The following is a description of a gene set: studied in species Homo sapiens Human Gene Set: GSE25087_FETAL_VS_ADULT_TREG_UP from publication Mold JE, Venkatasubrahmanyam S, Burt TD, Michaëlsson J, Rivera JM, Galkina SA, Weinberg K, Stoddart CA, McCune JM (PMID 21164017) We compared differences in fetal and adult T cells by performing whole genome profiling on sort-purified T cells (naïve CD4+ and Treg cells) from human fetal specimens (18-22 gestational weeks) and adult specimens (age 25-40 years old). Fetal and Adult Naïve CD4+ T cells phenotype: CD3+CD4+CD45RA+CCR7+CD27+, Fetal and Adult CD4+CD25+ Treg phenotype: CD3+CD4+CD25bright Genes up-regulated in comparison of fetal regulatory T cell (Treg) versus adult regulatory T cell (Treg)., and this is the list of marker genes: APOO, HSP90B1, VCP, KDM5B, MAN2A2, RAD21, SMCO4, LAMP3, NDUFB7, GRAMD1B, GSTP1, PIGY, BANF1, CSRNP1, HILPDA, YTHDF2, EVI5, SUCLA2, TNIP3, SLC25A43, TOX, CTPS1, KSR2, BTNL9, RAB43, TUBA1C, MAP3K20, CEP85, DHCR24, TRIO, DOLPP1, EPB41L2, AIF1, LRRC32 (leucine rich repeat containing 32), DNAH11, UBA2, PTGFRN, XPNPEP1, RRAS2, VDR, DACT1, NFKBIE (NFKB inhibitor epsilon), MREG, PLAG1, KHDRBS1, CASP3 (caspase 3), DYNC1I2 (dynein cytoplasmic 1 intermediate chain 2), RHOA, FAF2, STIP1, EVA1B, CXCL3 (C-X-C motif chemokine ligand 3), PTPRK, SLC18A2, DRAP1, CXCL1, NPM3, KIAA1586, NHS, GRK3, MACIR, CORO2B, VRK2, GTF2H5, CHCHD4 (coiled-coil-helix-coiled-coil-helix domain containing 4), PSME1, ACYP1, UTP14C, AGRN, EIF2S1, PRMT1, LINC00487, ZNF823, ADPRH, MCCC2, TMEM237, CDKN2B, GRHPR, HIC1, UBA5, GNB4, SLC25A20, ZNF404, FEN1, KLHL23, SCLT1, TRAF4, ZNF827, FURIN, RPA1, NDUFA9, CYP1A1, STAT1 (NCBI Gene Id 6772), ILDR2, ATF4, MRPL15, SIAH2, ACAA2, CMPK2, HNRNPK, LRRC59, RNGTT, TTTY14, GCN1, VBP1, BMAL2, PPIF, MYH10, TFRC, CYBB, PDIA6, GNG2, SLC29A1, ILK, TRIP6, SLC39A1 (solute carrier family 39 member 1), TIMELESS, ITGAE, ERP44, POMP, LARP4 (NCBI Gene Id 113251), CYFIP1, ADIPOR2, TNFRSF18, SLC19A1, TOP1MT, ZNF667-AS1, PMCH, PSMD14, DYNC2I1, LAMTOR5, SLC7A11, CTDSPL, TMEM139, EIF4G2, CABLES1, PRDX3 (peroxiredoxin 3), H2AC6, LZIC, HSPA5, ACYP2, EHD2, KLHL42, PSME2, SAP18, GLO1, IL1B, ATPAF1, STARD7, CANX, RHOC, TUBA1B, ASMTL, LTB, GNG5, SDC4 (syndecan 4), C17orf49, LSM3 (LSM3 homolog, U6 small nuclear RNA and mRNA degradation associated), CAD, NUP62, PTGR1 (prostaglandin reductase 1), LUZP1, BRD7 (NCBI Gene Id 29117), DENND11, SRP14, DDX49, MRPL27, EPHX2, HEY1, SAMSN1, HMGB3, FARP1, ESD, NOTCH2, YY1, ARPC1B (NCBI Gene Id 10095), BATF, STAMBPL1, TXNL4A, BRCA1, CDK2AP1, PXMP2, NDFIP2, MRPL13, CCND2, MTHFD1L, MCM2, TLR2, LRP4, HYOU1, SLC25A23, BCAT1 (NCBI Gene Id 586), UQCRH (ubiquinol-cytochrome c reductase hinge protein, NCBI Gene Id 7388), SCCPDH, IER3, CTTN, RALGPS2, CD200